The following is a description of a gene set: species: Mus musculus from publication Chen Y, Wang X (PMID 31504780) Mouse Gene Set: MIR_7007_5P Genes predicted to be targets of miRBase v22 microRNA mmu_miR_7007_5p in miRDB v6.0 with MirTarget v4 prediction scores > 80 (high confidence targets)., and this is the list of marker genes: Gm10413, Map4, Cars1, Selenof, Rheb, Btbd35f4, Rab14, Ttbk1, Slc25a19, Kansl1, Man1a2, Cyp26b1, Svip, Epha6, Pak3, Dhrs11, Ankrd28, Tnr, Stard4, Epsti1, Gpr101, Kctd8, Ror1, Ap1s1, Cpne3, Slc25a32, Exo1, Rabggta, Lactb, Cyp4a12b, Appl1, Edem1, Yy1, Btbd35f11, Dcaf10, Deptor, Hnf4a (NCBI Gene Id 15378), Crym, Appl2, Camta1 (NCBI Gene Id 75679), Kif3b, Fbxl17, Gtpbp10, Smad1, Dipk2a, Pcdh11x, Elavl4, Atg5, Trio, Btbd35f27, Gdap1l1, Btbd35f1, Maf, Nkain2, Hsf2bp, Agtr2, Wdr33, D7Ertd443e, Insig2, Asz1 (ankyrin repeat, SAM and basic leucine zipper domain containing 1), Ovol2, H2-T23, Rbm4b, Msrb3, Mc2r, Slf2, Lman1, Avl9, Notch2, Tiam1, Dync2i2, Palmd, Emc1, Dgcr8 (NCBI Gene Id 94223), Dusp1, Fdx1, Asb13, Dyrk1a, Rbm46, Jpt2, Btbd35f10, Gckr, Inpp4a, Ptprn2, Tfap2b, Stx17 (NCBI Gene Id 74595), Arnt, Plxna2, Pramel5, Kalrn, Btbd35f28, Zkscan8, Pld5, Palb2, Osr2, Ube4a, Pdcl, Pramel21, Myrf (NCBI Gene Id 386531), Ccny, E2f2, Btbd35f5, Shc4, Zfp456, Slc49a4, Clec9a, Stpg3, Lyz3, Tmx2, Cfl1, Rbpms, Lysmd4, Fbxw11, Sez6l2, Erc1, Tnpo1, Pramel24, Fscn1, Btbd35f16, Usp37, Bdh2, Tbl1xr1, Btbd35f7, Cyp4a12a, Pramel4, Hmg20a, Kpnb1, Psors1c2, Col1a1, Gpr107, Mfsd10, Vmn2r42, Btbd35f21, Mpg, Grem2, Zfp352, Gata2, Xkr8, Cers5 (ceramide synthase 5), Nadk2, Pbrm1 (polybromo 1), Ogt, Rwdd1, Fundc1, Zmat3, Plpp6, Mef2d, Pcdhga12, Zfp963, Bambi, Ikzf2, Pggt1b, Adam28, Zbtb8b, Rpgr, Pramel61 (PRAME like 60), Mecp2, Abcd2, Rfc2, Ppp3r1, Jph4, Jarid2, Btbd35f18, Cxcl12, Ssh2, Gm773, Lrfn5, Cdk6, Btbd35f13, Fam177a2, Kras, Il1rl1, Med1, Piezo2, Ralyl, Btbd35f2, Prokr1, Tmem109, Aggf1, Cldn12, Cramp1, Six5, Smarcc2, Slc1a3, Grpr (NCBI Gene Id 14829), Btbd35f17, Nemp1, Akr1c14, Cep43, Btbd35f3, Btbd35f20, Lpp, Btbd35f23, Ston1, Mmp16, Htr2c, Prkar2a, Ark2c (NCBI Gene Id 72870), Ttc14, Car12, Cmpk2, Grap2, Tnrc6b, Btbd35f15, Cep170, Rhobtb2 (Rho-related BTB domain containing 2), Hnrnpdl, Cdh7, Raph1, Zfr, Csmd1, Lrrn1, Tmed8, Tet1, Lamc1, Btbd35f12, Mob2, Rcbtb1, Rab5if, Tm9sf1, Supt16, Mcu, Notch4, Crppa, Socs2, Adam22, St8sia6, Fchsd2, Igsf1, Gorab, Osbpl11, Bach2, Lsm12, Gm5795, Tub, Snx12, Plagl2